Given this list of marker genes KAT6B, MED12, TBC1D24, PTH1R, RECQL, KCNN3, NPR3, ADH5, here is a description of the gene set: Human Gene Set: HP_LONG_THUMB Length of the thumb is greater than normal. Long thumb species: Homo sapiens